The following is a description of a gene set: Any process that modulates the activity of a transporter. species: Mus musculus Mouse Gene Set: GOBP_REGULATION_OF_TRANSPORTER_ACTIVITY, and this is the list of marker genes: Akap7 (A kinase anchor protein 7), Tmem74, Apoa2, Nlgn2, Bcl2, Cacnb4, Scn1b, Akap9, Dysf, Fgf14, Sco1, Calm3, Kcnq1, Stimate, Stim1, Atp1b1, Slmap, Nedd4l, Wnk3, Cnih3, Ahnak, Cltrn, Ubqln1, Plcg2, Oprm1, Mink1, Prkcd, Kctd7, Sumo1, Pln, Crhbp, Lrrc52 (NCBI Gene Id 76868), Neto1, Mrln, Pirt, Tlr9, Mapk8ip2, Gsto1, Reln, Osr1 (odd-skipped related transcription factor 1), Strit1, Ywhae, Hamp2, Stim2 (stromal interaction molecule 2), Kcnrg, Cnih2, Mmp9, Slc5a11, Cacng4, Kcne5, Cacna1f, Tesc, Gal, Abcb1a, Lrrc26, Akap6, Atp2a1, Ikbkb, Ptpn3, Trpc6, Ripk1, Zfas1, Cacna1d, Nlgn3, Cacng2, Ednra, Nedd4, Galr2, Rasgrf1, Scn2b, Homer1, Stac2, Epo, Fgf12, Actn2, Camk2d, Stac, Cacng5, Htt, Hamp, 1810037I17Rik, Crbn, Shisa9, Stac3, Myo5a, Gpd1l, Slc5a3, Kcne3, Ace2, Edn1, Chp1, Cbarp, Crh, Hspa2, Coa8, Ahcyl1, Pcsk9, Cacng7, Nppa, Cftr, Scn3b, Grp, Slc5a1, Ywhah, Cracr2a, Shisa7, Hap1, Tcaf1, Park7, Gsg1l, Jph3, Drd2, Pkd2, Shank1, Fkbp1b, Wwp2, Calm2, Adipoq, Atp7a, Calm1, Hrc, Jsrp1, Sphk2, Jph2, Oxsr1, Lrrc38, Ppif, Cacnb3, Cav1, Cav3, Kcne2, Dapk1, Atp1b3, Hpca, Tescl, Atpsckmt, Ndufa4, Ank2, Ins1, Stk39, Cox17, Rasgrf2, Kcne1, Smim6, Gstm7, Nlgn1, Taco1, Syngr3, Gnb5, Drd4, Kcnj8, Cttnbp2nl, Pim1, Actb, Snca, Chrm3, Nipsnap2, Sln, Ndfip1, Kcnab1, Abcc9, Ndfip2, Ctss, Casq2, Lrrc55, Rangrf, Vmp1, Cnksr3, Phb2, Fxyd1, Fgf13, Ank3, Fkbp1a, Scn4b, Fxyd2, Rnf207, Nr3c2, Adrb2, Wnk2, Vamp2, Fhl1, Kcnj1, Cacng8, Asph, Cacnb2, Sri, Selenon, Dmd, Gpr35, Plcb1, Abcb1b, Agrn, Itgb1 (integrin beta 1 (fibronectin receptor beta)), Cacng3, Prrt1, Tmem168, Casq1, Ehd3, Ins2, Slc9a1, Gopc, Nherf1, Fmr1, Atp1b2